The following is a description of a gene set: Human Gene Set: GOBP_DESMOSOME_ASSEMBLY studied in species Homo sapiens A cellular process that results in the aggregation, arrangement and bonding together of a set of components to form a desmosome. A desmosome is a patch-like intercellular junction found in vertebrate tissues, consisting of parallel zones of two cell membranes, separated by an space of 25-35 nm, and having dense fibrillar plaques in the subjacent cytoplasm., and this is the list of marker genes: PRKCA, CDH1, PKP3, JUP, PKP1, DSG3, PKP2